The following is a description of a gene set: species: Homo sapiens Nucleotide GPCRs Human Gene Set: WP_NUCLEOTIDE_GPCRS, and this is the list of marker genes: P2RY1, ADORA3, LPAR6, ADORA2A, P2RY6, LPAR4, ADORA1, LTB4R, P2RY2, P2RY4, ADORA2B